Given this list of marker genes GPR22, SLC43A1, CSH2, GRIK1, TEX14, CD34 (CD34 molecule), XYLB, DDX18, ATG16L1, CCDC85C, EVI2A, SEC14L1P1, H2AC18, KIAA0087, NAP1L3, RMND5B, CACNA1E, SDC2 (NCBI Gene Id 6383), KRT19P2, HLA-DOB, IGKV1D-13, CDK6, SLC28A1, SLC3A1, KLF17P1, ALDOB, NEUROD6, RAMP3, SUSD5, HOXA6, SSX1, AAK1, CNPY4, IRF4, WDR62, HNF4A, HTR5A, ARHGEF1, BIN2, SLC19A1, DDN, LILRB5, KRT36, RGS4, DYNC1I1, PMP22, RBM12B, LRRC32, DENND1C, ADGRE1 (adhesion G protein-coupled receptor E1), A1CF, ADGRA2 (NCBI Gene Id 84863), ULBP1, TAC3, FUT5, FICD (FIC domain protein adenylyltransferase), PCDHB17P, MCF2L2, ITFG2, DIO3, MRPL52, C19orf53, PCDHGB6, C1QA, CLDN17, SLC6A15, PLGRKT, ACVR2B, IER3IP1, TNFRSF11B (NCBI Gene Id 4982), OPHN1 (oligophrenin 1), DCBLD2, PCDHGA10, CYP21A2, SYCE1L, GFAP, ZBTB44, NPFFR1, TSR1, PAEP, TGM4, EIF3I, GRK6, WT1, PRL, NPY6R, HERC5, COL6A2, ADCY10, BMP8B, POLR2J4 (NCBI Gene Id 84820), PKMYT1, RAB40A, UCP1 (NCBI Gene Id 7350), TAS2R16 (NCBI Gene Id 50833), ADGRB3 (adhesion G protein-coupled receptor B3), DCLK2, SPATA31F2P, VAX2, GATA4, GREM1, CADPS, HOXC13, NPY, IFNA6, RASGRP3, BTNL3, SYNPO2L, CHRD, RAD54L2, ANKRD55, SNRPN, CTSW, FBXW4P1, AMACR, ZNF770 (NCBI Gene Id 54989), ALPP, WSCD1 (WSC domain containing 1, NCBI Gene Id 23302), PPIEL, LGR5, CPN1, ATP8B2, SLC66A1, TMEM179B, CADM3, CYP2U1, GABRB2, DDR2, B3GALT2, CCL19, RPAIN, UPB1, NRCAM, POU5F1B, CHST12, FOLR2, DND1, CLEC10A, RASGRF1, SELP, NOVA1, TAT, TCF20, EXOSC9, GTPBP10 (NCBI Gene Id 85865), GAS8-AS1, IL25, NR2E3, CD52, GNMT, TELO2, MKRN3, MYBBP1A, P2RX3, INHBC, ADCYAP1, SAGE1, RNF17, RPLP1, DLGAP2, HRH3, FOXN3-AS2, CRYGD, DMTN, AIPL1, MTAP, HNRNPA3P1, PDE1C, CNNM1, CHD5, KAT6A, SMG7-AS1, SSTR3, HRH2 (histamine receptor H2), SP3P, RAPGEF6, PCK1, DSG1, SYT2, MRPL41, IL3, SFTPB, APOF, APBB1 (NCBI Gene Id 322), LTB, F5, TERT, CLCN2, here is a description of the gene set: Genes down-regulated in double positive thymocytes: TCF3 knockout versus TCF12 knockout. We wanted to test the role of mammalian E proteins E2A and HEB in the development of T cells. Using a conditional deletion system in which these proteins are deleted at the DP stage of T cell development, we compared DP thymocytes deficient for E2A, HEB or both to wild-type thymocytes studied in species Homo sapiens Human Gene Set: GSE19923_E2A_KO_VS_HEB_AND_E2A_KO_DP_THYMOCYTE_DN from publication D'Cruz LM, Knell J, Fujimoto JK, Goldrath AW (PMID 20154672)